Given this list of marker genes SMAD1, FOXH1, PAX6, CITED1, USP9X, USP9Y, SMAD2, GATA4, TGIF1, TRIM33, SMAD3, SMAD6, here is a description of the gene set: species: Homo sapiens Binding to a common mediator SMAD signaling protein. Human Gene Set: GOMF_CO_SMAD_BINDING